Given this list of marker genes IARS2, IARS1, LARS2, VARS2, AARS1, DTD1, DTD2, AARSD1, LARS1, TARS2, VARS1, PRORSD1P, AARS2 (NCBI Gene Id 57505), here is a description of the gene set: species: Homo sapiens Any process which detects an amino-acid acetylated tRNA is charged with the correct amino acid, or removes incorrect amino acids from a charged tRNA. This process can be performed by tRNA synthases, or by subsequent reactions after tRNA aminoacylation. Human Gene Set: GOBP_AMINOACYL_TRNA_METABOLISM_INVOLVED_IN_TRANSLATIONAL_FIDELITY